The following is a description of a gene set: species: Homo sapiens Human Gene Set: HP_ENTRAPMENT_NEUROPATHY Malfunction of a peripheral nerve resulting from mechanical compression of the nerve roots from internal or external causes and leading to a conduction block or axonal loss. Entrapment neuropathy, and this is the list of marker genes: GNAS, ARSB, IDUA, GNPTAB, GPR101, LMNA, IDS, B2M, CA2, SH3TC2, TTR, SAA1, COMP, AIP, GSN, CCND1